The following is a description of a gene set: Sclerosis of the epiphyses of the phalanges of the fingers, leading to an increased degree of radiopacity (white or ivory appearance) in X-rays. Ivory epiphyses of the phalanges of the hand Human Gene Set: HP_IVORY_EPIPHYSES_OF_THE_PHALANGES_OF_THE_HAND studied in species Homo sapiens, and this is the list of marker genes: TRPS1, SRCAP, ERCC6, ERCC8, EIF2AK3 (NCBI Gene Id 9451), TONSL